Given this list of marker genes FGF17, KLB, FGF23, PLCG1, FGF16, FGF19, FGFR4, FGF4, FGF1, FGF2, FGF8, FGF6, FGF20, FGF18, FGF9, here is a description of the gene set: Human Gene Set: REACTOME_PHOSPHOLIPASE_C_MEDIATED_CASCADE_FGFR4 species: Homo sapiens Phospholipase C-mediated cascade; FGFR4